Given this list of marker genes Cenpl (NCBI Gene Id 98714), H2ac19, Itgb3bp, Cenpp, H4c18, H2ac8, H2bc26, H2bc14, H4c11, H2bc23, H4c4, Cenpc1, H2ac24, H2ac13, H4c16, H2bc6, Cenpi, Smarca5, H2bc4, H2ac10, H2bc15 (H2B clustered histone 15), Cenpn, Mis18bp1, H2ac11, H2bc7, Rsf1, Cenpx, H2ac4, Mis18a, H4c1, H2bc13, H2bc21, Ruvbl1, H4c2, H2bc11, Cenpq, H2aj, H2ax, H2ac23, H2bc12, Cenpu, Rbbp7, H2bc24, H2ac6, Npm1, H2az2, H4c8, H2ac20, H2ab1, H4c6, H4c12, H2ab2, H2bc1, H2bc9, Hjurp, H4c9, H2bc8, H2ab3, H2ac18, Oip5, Cenpw, Cenpt, H2bc22, Cenps, H4c3, Rbbp4, H4c14, Cenpm, Cenpo, H2bc3, H2ac15, H4c17, Cenpa, Cenpk, H2ac22, H2ac12, H2ac7, Cenph, here is a description of the gene set: Deposition of new CENPA-containing nucleosomes at the centromere Mouse Gene Set: REACTOME_DEPOSITION_OF_NEW_CENPA_CONTAINING_NUCLEOSOMES_AT_THE_CENTROMERE studied in species Mus musculus